Given this list of marker genes CSF1, TCF4, IPCEF1, MCOLN2, LARP7, ABITRAM, UTRN, TH, ZSCAN2, COL4A3, MTREX, USP54, ALKBH8, RASAL1, FGF16, TRIM2, CRYBA2, GRK5, NDFIP1, RSRC1, MAP3K8, CST7, GAS2L2, TWSG1 (NCBI Gene Id 57045), MARVELD2, MIS18A, ZNF644, COL5A3, IQCH, NRG2, TMTC4, GARIN3, UNC13B, EGR2, STEEP1, TRH, LCOR, WLS, TEX10, ENTREP2, TULP2, CCKAR, SBK1, FANCC, MTF2 (NCBI Gene Id 22823), PRUNE2, PRPH, PPIP5K2, SSBP2, TMEM247, CRYGN, MUC4, MRPL19, ENDOD1, TESMIN (NCBI Gene Id 9633), TRO (trophinin), ARCN1, UHMK1, NKX3-2, SLC6A12, ALPK2, NFKBIZ, ADAMDEC1, RRBP1, TMEM239, ACTN1, MYB, PIK3R3, CAMK2D, LGI3, ITIH1, TLE4, JARID2, MARCKSL1, CCT4, PPP1CB, FAM53B, KCNK16, TAGAP, BMPR2, GRM8, NOL7, POM121, HTRA4, PIK3CD, CR1L, PRSS23, CPA2, KRR1, TNFRSF4, DDN, NIPAL1, ASTN1, CELA3B, FGF13, PLB1, CDK13, PVALB, P2RY1 (NCBI Gene Id 90963), SMG1, SGK1, PROP1, MBTD1 (mbt domain containing 1), PSMA3, LRFN2, LTV1, HNRNPK, ZBTB6, WDR62, TRA2A, MCF2, NCF1, ITGA6, CLRN1, PNMA8B, C1QL1, HIPK3 (homeodomain interacting protein kinase 3), TACC2, XRCC5, YY1, CHML, LEPR, PARD6G, CPT1C, METTL2B, FBXO7, RCN3, ADAMTS6, RANBP2, CAND1, PLCB4, PPM1H, EYA2, ARHGEF3, LCK, CDHR5, ADAM33, PTGDS, PPP6R2, GOLPH3, SIRT1, ATP11C, SMIM23, CFAP20, IGFALS, IRAG2, KRTAP15-1, LRRC58, HSPA4L, RCAN1, PBRM1, BRD9, IFNG, PAN2, RILPL2, PCMT1 (NCBI Gene Id 5110), GLG1, MED6, RAD50, DNAL4, DNMT3A, RABGAP1L, WNT2B, RIOK2, TCERG1, VAV3, KCTD9, PROKR1, TRIM8, ADRA2A, AFTPH, PRNP, EN1, FUBP1, MARCKS, ENPEP, USP33, ZNF823, GFOD1, IQCF5, TUBGCP2, HACE1, COMMD6, KPNA7, BLZF1, PDCD1, UPK3BL1, CABS1, FAM83D, PRMT8, BARHL1, ZZZ3, DCAF15, DDX52, ZNF784, P4HA2, TSPYL1, APOE, NAA30, CARD14, here is a description of the gene set: Genes down-regulated in T conv cells: IL35 treated versus untreated. species: Homo sapiens Regulatory T cells (Tregs) play a critical role in the maintenance of immunological self-tolerance. Naïve human or murine T cell treatment with the inhibitory cytokine IL35 induces a regulatory population, termed iTR35, that mediates suppression via IL35, but not IL10 or TGFβ, neither express nor require Foxp3, are strongly suppressive in five in vivo models, and exhibit in vivo stability. Treg-mediated suppression induces iTR35 generation in an IL35- and IL10-dependent manner in vitro, and in inflammatory conditions in vivo in Trichuris-infected intestines and within the tumor microenvironment, where they appear to contribute to the regulatory milieu. iTR35 may constitute a key mediator of infectious tolerance and may contribute to Treg-mediated tumor progression, and ex vivo-generated iTR35 may possess therapeutic utility. from publication Collison LW, Chaturvedi V, Henderson AL, Giacomin PR, Guy C, Bankoti J, Finkelstein D, Forbes K, Workman CJ, Brown SA, Rehg JE, Jones ML, Ni HT, Artis D, Turk MJ, Vignali DA (PMID 20953201) Human Gene Set: GSE24210_IL35_TREATED_VS_UNTREATED_TCONV_CD4_TCELL_DN